The following is a description of a gene set: Reactome Pathway: Mitochondrial ABC transporters Mammalian ABC transporters are usually found on the plasma membrane and on organelles such as the ER and peroxisome but a small number are also located on the mitochondria. Here they are thought to play roles in heme biosynthesis and iron-sulphur cluster synthesis (Burke & Ardehali 2007). species: Homo sapiens part of: ABC-family protein mediated transport, and this is the list of marker genes: ABCB7 (ATP binding cassette subfamily B member 7), ABCB10, ABCB8, ABCB6